The following is a description of a gene set: Binding to a vitamin, one of a number of unrelated organic substances that occur in many foods in small amounts and that are necessary in trace amounts for the normal metabolic functioning of the body. species: Mus musculus Mouse Gene Set: GOMF_VITAMIN_BINDING, and this is the list of marker genes: Cyp2r1, Vdr, Gpt2, Dhtkd1, Pcx, Acacb, Sptlc1, Gad1, Hlcs, Mmut, P3h3, Oat, Egln3, Dhfr, Ttpa, Pdxk, P4ha1, Mtarc2, Cubn, Opn3, Sptlc2, Hacl1, C8g, Abca4, Fasn, Agxt2, Mtr, Cyp2w1, Accsl, Got2, Gadl1, Mmab, Tcn2, Rbp2 (NCBI Gene Id 19660), P4ha3, Phyh, Rbp3, Slc19a1, Gnmt, Tktl1, Pygm, Scly, Bspry, Mthfsl, Pygl, P3h1, Rbp4, Psat1, Tpk1, Mmachc, Adh7, Rbp1, Shmt2, Crabp2, Ggcx, Rbp7, Gcat, Opn4, Egln2, Pygb, Cblif, Tyms, Comp, Lrat, Cbs, P4htm, Pdxdc1, Izumo1r, Folr2, Ilvbl, Ftcd, Ogdh, Lmbrd1 (NCBI Gene Id 98639), Ogfod1, Plod2, Pnpo, Agxt, Sds, Sptlc3, P4ha2, Plpbp, Nfs1, Pam (NCBI Gene Id 227401), Calb1, Uros, Rlbp1, Aldh1a2, Tkt, Plod1, Phykpl, Stra6, Got1, Slc46a1, Cisd1, Sardh, Alas1, Kynu, Gad2, Accs, Egln1, Srr (NCBI Gene Id 27364), Gc, Got1l1, Npc1l1, Thnsl2, Mtarc1, Mthfs, Opn5, Pank3, Csad, Sdsl, Ddc (dopa decarboxylase), Sgpl1, S100g, Hdc, Tat, Aadat, Alb, Kyat3, Gpt, Ogfod3, Akr1b8, Adh4, Etnppl, Rho, Kyat1 (NCBI Gene Id 98869), Mocos, Gldc, Dbh, Acaca, Alas2, Dmgdh, Cth, Tktl2, P3h2, Abat (NCBI Gene Id 57428), Afm, Cd320, Plod3, Shmt1, Ogfod2, Crabp1, Folr1 (NCBI Gene Id 14275)